Given this list of marker genes WNT11, MIR152, MIR195, RGCC, MIR205, FGFR1, here is a description of the gene set: species: Homo sapiens Any process that decreases the rate, frequency or extent of the appearance of a fibroblast growth factor due to biosynthesis or secretion following a cellular stimulus, resulting in an increase in its intracellular or extracellular levels. Human Gene Set: GOBP_NEGATIVE_REGULATION_OF_FIBROBLAST_GROWTH_FACTOR_PRODUCTION